Given this list of marker genes Lmod1, Zfp738, Tlcd4, Zfp866, Trim34a, Efemp1 (epidermal growth factor-containing fibulin-like extracellular matrix protein 1), Zfp973, Syn1, Maoa, Prrx1, Mtm1, Elovl7, Eif4e3, Zfp965, H2-M2, Zfp1009, Ublcp1, Magi1 (membrane associated guanylate kinase, WW and PDZ domain containing 1), Fam53c, Msx3, Nps, Med10, Asb1, Tinag, Kdm7a, here is a description of the gene set: species: Mus musculus from publication Chen Y, Wang X (PMID 31504780) Genes predicted to be targets of miRBase v22 microRNA mmu_miR_879_3p in miRDB v6.0 with MirTarget v4 prediction scores > 80 (high confidence targets). Mouse Gene Set: MIR_879_3P